Given this list of marker genes EDNRA, GIPR, GHRHR, CAP1, CALCA, ADORA3, ADORA2B, ADORA2A, ADRB2, CAP2, here is a description of the gene set: Human Gene Set: MODULE_454 Genes in the cancer module 454. species: Homo sapiens